Given this list of marker genes Fbxo8, Syvn1, Ddx21, Kif11, Nfatc3, Ppp1r3b, AI182371, Ssb, Nr5a2, Sfrp2, Bmpr2, Qki, Tle1, Spred1, Appl1, Tm7sf3, Lrp1b, Fli1, Itga6 (integrin alpha 6), Arap2, Ube2b, Kdm2b, Nudt4, Pafah1b1, Fam76b, Lhx5, Slain2, Dek, Foxp1, Gtf2i, Tle4, Csnk1g3, Tgfb3, Hivep2, Casp8ap2, Mbnl2, Isoc1, Pde10a, Btbd1, Mapk1, Hikeshi, Nlgn1, Tra2a, Asic4, Rab3gap2, Rab11fip2, Eps15l1, Il5ra, Ptbp3, Zfp704, Dgkd, Olfml2b, Tcf3, Actr3, Map2, Ubtf, Rsf1, Dcbld2, Scai, S100pbp, Srsf11, Hes1, Mpv17l, Rcc1, Sox9, Dcaf1, Cpeb2, Paxbp1, Mycbp2, Zfp318, Scn2a, Tab3, Rab10, Frs2, Cwc22, Zmiz1, Syt14, Wac, Dcaf6, Myf5, Btg2, Hbp1, Oosp1, Opa1, Ubn1, Itm2c (NCBI Gene Id 98594), Mef2d, Kcnip2, Car10, Hectd1, Ppp4r3b, Thoc1, Pm20d2, Armc10, Sde2, Tbc1d15, Syngr3, Atad2, Cilk1, Arhgap44, Vezf1, Pcdh8, Usp32, Jag2, Srsf1, Mycn, Sgtb, Rab6b, Spen, Npbwr1, Cnot6l, Spata13, Cnr1, Sanbr, Rad21, Lgr4, Usp31, Plekhm3, Ppp1r15b, Zmat1, Xpo7, Zic1, Otx2, Mark1, Rtn1, Nrp2, Mycl, Abcb1a, Dennd2b, Zfyve21, Herc1, Tasp1, Zbtb14, Thrb, Aak1, Hmgxb4, Gpr37, Akap1, Ercc5, Frem2, Arih1, Glcci1, Klhl24, Mcu, Slc25a16, Zfp219 (NCBI Gene Id 69890), Cntrob, Ubn2, Tmem68, Ier5, Dcaf7 (NCBI Gene Id 97751), Mid2, Pdzrn3, Fgfr2, Pdia3, Cab39, Ubxn7, Zfpm2, Laptm4a, Mfsd1, Eif4g3, Erf, Ripply2, Tusc3, Cep72, Myo5a, Snrpb2, Acr (NCBI Gene Id 11434), Wdhd1, Hacd2, Pyroxd1, Btf3l4, Ythdf3, Ptpre, Uox, Fbxo34, Calu, Cdc42ep3, Zfp850 (zinc finger protein 850), Nkiras1, Mex3b, Scx, Trpm7, Ppp1r2, Add3, Cntn1, Unkl, Ppp1r21, Fmnl3, Btaf1, Tmem26, Klhl7, Rbbp6, Ap1s3, Nphp3, Rprd1b, Rerg, Wdr26, Rrm2b, Rev3l, Wnt5a, Dmtf1, Il4, Tns3, Spock3, Rhot1, Prpf38b, D630023F18Rik, Basp1, Kbtbd2, Adcy6, Irx3, Gria3, Acvr2b, Cldn12, Bnip2, Kctd12, Setdb2, Rbm46, Tm4sf4, Adamts5, Camk2d (calcium/calmodulin-dependent protein kinase II, delta), Zfp518a, Rcan2, Ino80d, Thbs2, Prdm16, Pik3c2a, Ppfia2, Il10rb, Fabp3, Dcx, Ncapg2, Erbin, Kdm7a, Wdr35, Emp2, 9330159F19Rik, Txlng, Stk40, Slc20a2, Cdh20, Bhlhe40, Etl4, Nbea, Arid4b, Cert1, Golga7, Nfkbia, Tjp1, Cnbp, Camta1, Slc38a9, Pum2, Dcun1d4, Rhoa, Col4a1, Rasef, Foxn2, Bltp1, Arhgap20, Rictor, Cftr, Yy1, Dock11, Sh3gl3, Fbxo38, Nr3c1, Id1, Nxt2, Phyhipl, Tet3, Nudt11, Nr2f2, Nptn, Rnf144a, Psip1, Grhl3, Baz1b, Cacna2d1, Dlx2, Pfkfb3, Gulp1, Akap9, Fbxo45, Fbxo43 (NCBI Gene Id 78803), Zbtb41, Abcd3, Col11a1, Rnf115, Larp4b, Lin9, Cand1, Akap12 (NCBI Gene Id 83397), Ptms, Ppp1r3f, Rif1, Usp42, Usp25, Hip1, Cdc14b, Rabggtb, Srsf2, Bnc1, Ifit1bl1, Tcerg1l, Arhgef3, Eea1, Aqr, Acvr1, Npy1r, Mllt6, Tpm1, Lats1, Rnf223, Ebf3, Gabrg1, Nckap5, Crk (v-crk avian sarcoma virus CT10 oncogene homolog), Skint10, Igf1r, Mllt10, Rsrp1, Dnali1, Tmtc2, Ccnq, Plag1, Utrn, Psd3, Ice1, Myo9a, Grm5, Crebzf, Selenok, Capza2, Plk1, Ppp4r2, Atf2, Fa2h, Nfat5, Mmab, Golim4, Spin1, Col13a1 (NCBI Gene Id 12817), C1qbp, Dennd4a (NCBI Gene Id 319526), Kmt2e, Rb1cc1 (NCBI Gene Id 77109), Cacna1b, Gls, Fndc3a, Efna5, Mt4, Vcf2, Slc8a1, Mageb3, Myct1, Tmem39a, Gramd4, Akap6, Foxd3, Grk5, Lrp6, U2surp, Ppp3ca, Hhip, Rab14, Sfpq, Cpsf6, Tecrl, Rfx7, Dcc, Zfp280d, Cpne2, Kdm6a, Ankrd44, Pnisr, AI597479, Myt1l, Ptpra, Mast4, Slc25a40, Tead1, Pabpc4l, Adss2, Ciart, Vkorc1l1, Magi1, Sbno1 (strawberry notch 1), Lemd3, Npr3, Fosl2, Polr2k, Ctla4, Spry1, Prkacb, Inpp4a (NCBI Gene Id 96938), Trpc5, Hectd2, Ccny, Pcdh11x, Plppr5, Gdap2, Hook3, Sall3, Lrrc1, Clca3a2, Tnfrsf11b, Man1a2, Rnf38, Kpna3, Snx14, Jag1, Taok1, Pou2af3, Foxo1, Efcab2 (EF-hand calcium binding domain 2), Hnrnpa1, Spry2, Gata3, Nexmif, Tut4, Golga2, Cdk2ap2, Slc39a10, Arfip2, Plcl2, Naaladl2, Pias1, Cnnm4, Ncoa2, Nasp, Dach1, Aktip, Bmpr1a, Gpalpp1, Hmgcr, F3, Lysmd3, Smo, Ano4, Brd1, Adcyap1, Cpeb3, Bmal1, Hdac9, Bdp1, Chd1, Slc6a17, Pcgf5, Nup35, Zfp248, Atp6v1h, Clspn, Ppp4r3a, Dmxl2, Btbd3, Slc18a2, Unc79, Ccdc126, Syf2 (SYF2 homolog, RNA splicing factor (S. cerevisiae)), Unc119b, Zfp800, Hivep1, Rab11fip3, Fnip1, Zfyve16, Cnot6, Sephs1, Hnrnpd, Tcf20, Cry1, Zbtb49, Plpp3, Tubgcp5, Sp4, Mtf1, Ormdl1, Cul1, Bfar, Mdm1, Cnksr3, Sp9, Mageb16, Zcchc24, Uty (NCBI Gene Id 546404), Oxr1, Tasor, Ikzf2, Mblac2, Cadm1, Psmd5, Sspn (sarcospan), Mitf, Rnf170 (NCBI Gene Id 77733), Mospd2, Jph1, Cabp4, Klhl2, Ccrl2, Ik, Pum1, Plekha6, Hcrtr2, Map4 (microtubule-associated protein 4), Mdm4, Dock1, Herc2, Slc10a4, Carmil1, Gng2, Hycc2, Zmym6, Ubl3, Nktr, Tbc1d4, Psd2, Bdnf, Efs, Klf4, Edil3, Apaf1, Septin9, Cecr2, Col1a2, Arhgef33, Prr12, Bach2, Smarca5 (NCBI Gene Id 93762), Dll1, Zmynd8, Tec, Traf3ip1, Gnpat, Ralgds, Olfm3, Ubr1, Rnf24, Usp12, Ube3c, G2e3, Dll4, Kmt2c, Mecom, Atad5, Nkx2-9, Tob1, Neurog2, Med14, Smyd3, Gp1ba, Creld2, Fzd6 (frizzled class receptor 6), Cbx5, here is a description of the gene set: Mouse Gene Set: LET_7B_3P from publication Chen Y, Wang X (PMID 31504780) Genes predicted to be targets of miRBase v22 microRNA mmu_let_7b_3p in miRDB v6.0 with MirTarget v4 prediction scores > 80 (high confidence targets). species: Mus musculus